The following is a description of a gene set: studied in species Mus musculus Mouse Gene Set: GOCC_PROTEIN_FOLDING_CHAPERONE_COMPLEX A protein complex required for the non-covalent folding or unfolding, maturation, stabilization or assembly or disassembly of macromolecular structures. Usually active during or immediately after completion of translation. Many chaperone complexes contain heat shock proteins., and this is the list of marker genes: Ptges3, Ruvbl2, Cct8, Cct8l1, Hsp90ab1, Stip1, Tcp1, Sdf2l1, Cct7, Hspb8, Cct3, Rpap3, Ptges3-ps, Psmg2, Hsf1, Hspa8, Sdf2, Pih1d2, Dnajc9, Psmg1, Spag1, Ppp5c, Tsc1, Cct6b, Ccdc47, Cct6a, Dnajb11, Bag3, Cct2, Cct5 (NCBI Gene Id 12465), Stub1, Dnaaf2, Ruvbl1, Wdr83os, Cdc37, Bag2 (BCL2-associated athanogene 2), Cct4